The following is a description of a gene set: from publication Feng A, Pokharel MD, Liang Y, Ma W, Aggarwal S, Black SM, Wang T (PMID 38674159) Human Gene Set: FENG_SEPSIS_HIGH_RISK_ROS_UP species: Homo sapiens, and this is the list of marker genes: PRDX2, PTGS2, KRT1, CCT4, IFNG, DHRS4, BCL2, JUN, TYSND1, HSPD1, CROT, HACL1, GSTP1, CCL5, CCT3, DNAJC9, DNAJA3, EPHX2, IL12RB1 (NCBI Gene Id 3594), GSS, HSPA9, MYC, FMO5, SLC27A2, SRC, PRDX4